Given this list of marker genes ROS1, DAPK2, PRR13P2, GOLGA8B, IRX1, GUSBP5, LINC02277, CABLES1, ETV5, CLDN6, SFTPA1, MBIP, HAS3, BMP3, LINC01393, SFTPB, C10orf90, SMARCA5, KCNJ15, SUSD2, BAMBI, LMO7DN (LMO7 downstream neighbor), CHIA, NDNF, ATP11A-AS1, TSPAN13, ATP11A, AGER, NT5ELP, ACOXL, CPM, NKX2-1-AS1, CRLF1, FAM41C, SLC10A2, NKX2-1, IRX2, LINC01331, LINC03007, PTCSC3, SFTPC, WIF1, NPC2, ESYT3, SFTA3, LINC02026, here is a description of the gene set: from publication Cao J, O'Day DR, Pliner HA, Kingsley PD, Deng M, Daza RM, Zager MA, Aldinger KA, Blecher-Gonen R, Zhang F, Spielmann M, Palis J, Doherty D, Steemers FJ, Glass IA, Trapnell C, Shendure J (PMID 33184181) The gene expression program underlying the specification of human cell types is of fundamental interest. The study authors generated human cell atlases of gene expression and chromatin accessibility in fetal tissues. For gene expression, the study authors applied three-level combinatorial indexing to >110 samples representing 15 organs, ultimately profiling ~4 million single cells. The study authors leveraged the literature and other atlases to identify and annotate hundreds of cell types and subtypes, both within and across tissues. Our analyses focused on organ-specific specializations of broadly distributed cell types (such as blood, endothelial, and epithelial), sites of fetal erythropoiesis (which notably included the adrenal gland), and integration with mouse developmental atlases (such as conserved specification of blood cells). These data represent a rich resource for the exploration of in vivo human gene expression in diverse tissues and cell types. Human Gene Set: DESCARTES_MAIN_FETAL_BRONCHIOLAR_AND_ALVEOLAR_EPITHELIAL_CELLS species: Homo sapiens Marker genes curated from the annotated cluster as represented in the Descartes Human Gene Expression During Development database.